The following is a description of a gene set: Expression profiling of Rag2-deficient Ets1++ and Rag2-deficient Ets1-- mature NK cells and WT bone marrow progenitors, WT T cells, and WT Pro B cells Genes up-regulated in multipotent progenitors versus RAG2 knockout NK cells. Human Gene Set: GSE37301_MULTIPOTENT_PROGENITOR_VS_RAG2_KO_NK_CELL_UP studied in species Homo sapiens from publication Ramirez K, Chandler KJ, Spaulding C, Zandi S, Sigvardsson M, Graves BJ, Kee BL (PMID 22608498), and this is the list of marker genes: CD22, LONP2, MTERF2, FADS1, HSPD1, CALU (calumenin), SNX21, EIF2S3 (NCBI Gene Id 8422), UBP1, TNFSF8, FBLN2, MFSD4A, SLC26A1, SEC14L2, RTN3, ODC1, GPR19, SRPK2, WDTC1 (WD and tetratricopeptide repeats 1), AMY2A, SNTA1, SLC25A15, NELFCD, KIAA1191, ALDH1A1, PAQR7, METTL8, ADORA1, KCTD10, PKLR, SDHA, NUP88, GPAM, GUCA1A, KIT (NCBI Gene Id 5086), YWHAQ, BHMT, MIP, APLP2, TSNAX, TSC22D4, AQP9, CYP2E1, CCDC88A, DPP4, NAA80, MAP2K3, FAM107B, RMND5A (NCBI Gene Id 64795), BTRC, STAB1, SPPL3, PTPA, CSF2, FES, TM9SF3, LGALS4, ENTPD5, SLC2A2, DIPK2A, SPAST, PIGS, MAPK1, CCNI, ZBTB48, NOCT, DEF8, APOH, C5 (NCBI Gene Id 727), OAT, GRSF1, NPEPL1, CDK18, SLC2A1 (solute carrier family 2 member 1), XPR1, CYP1A2, STARD7, CCN4, COL4A4, UIMC1, KLC4, DUSP6, MAP4K4, PRKACA, RPA1, FTH1, RTL8B, USP15, CAPN7, PTPRE, NPC1, MERTK, POLG2, RHOQ, IL12RB2, RETREG2, CMTM8, FLT4, UGT2B17, PNPO, CAPRIN2, SLC7A8, NTRK3, VAMP3, RIN2, PGM1, SACM1L, ASRGL1, LSS, HOXB5, ZCCHC3, PTH1R, CPOX, MMP15, FURIN, MAOA, ANXA6, TMEM245, APOA1, RDX, TRABD, GANAB, NR2F1, TNNT1, SLC39A8, PGRMC1, SEPHS2, PRMT3, PPP6C, CRYL1, RAB34, LGALS7, GLE1, PAH, NCOA4, NME4, WBP1, CHMP1B, MAN1A1, TBCEL, ADGRE1 (NCBI Gene Id 2015), EXOC7, PSTPIP2, DVL1, ATP5F1A, MTCH1, RAB23, DDX5, SEC61A2, TP53INP2, MED22, USF1, SLC38A4, ACO2, QRICH1, ZNF467, FAM3A, SLBP, FAM32A, RCE1 (NCBI Gene Id 9986), NFYC, SULT1B1, C6orf62, STAG2, CD300C, EIF5, TRAPPC10, EIF2B1 (eukaryotic translation initiation factor 2B subunit alpha), PCMT1, ZFP30, PHLDB2 (NCBI Gene Id 90102), KRT13, ISOC1, CDK2, PPP3R1, DSC2, RRM2, ALDOB, ADD1, XPO7, CYP2A6, AMACR, USP48, SLC48A1, GAS6, DNAJC10, WBP11, FTL, DPP3, PLS3, DMBT1, MAZ, UBAP1, CSTF1, CYP3A43, CLN6, ABCC9, DHPS, TBX3, KANSL2